Given this list of marker genes PTPRZ1, PTN, MDK, ALK, here is a description of the gene set: part of: Signaling by ALK studied in species Homo sapiens The cytokines pleiotrophin (PTN) and midikine (MDK) were initially proposed to act as ligands for ALK. Binding of PTN or MDK to ALK either in cell-free assays or in intact cells was shown to stimulate signaling through IRS, SHC, PLC and PI3K and to support neurite outgrowth, growth and survival. The activating effects of PTN and MDK on the ALK receptor were not universally reproducible, however, despite eliciting similar downstream signaling to those with anti-ALK monoclonal antibodies. More recently, ALKAL1 and ALKAL2 have been identified as the physiologically relevant ALK ligands. Reactome Pathway: MDK and PTN in ALK signaling